Given this list of marker genes Vegfc, Vegfa, Flt4, Pgf, Vegfb, Vegfd, Flt1, here is a description of the gene set: electronically inferred by orthology from the curated human pathway part of: Signaling by VEGF Reactome Pathway: VEGF ligand-receptor interactions This event has been computationally inferred from an event that has been demonstrated in another species.<p>The inference is based on the homology mapping from PANTHER. Briefly, reactions for which all involved PhysicalEntities (in input, output and catalyst) have a mapped orthologue/paralogue (for complexes at least 75% of components must have a mapping) are inferred to the other species. species: Mus musculus